Given this list of marker genes CASP10, FASLG, RAB27A, FAS, NSMCE3, here is a description of the gene set: Decreased ability to react to a delayed hypersensitivity skin test. studied in species Homo sapiens Reduced delayed hypersensitivity Human Gene Set: HP_REDUCED_DELAYED_HYPERSENSITIVITY